Given this list of marker genes B4galt4, Alas1, Add1, Potegl, Pnp, Pde3a, Efna5, Plppr3, Surf2, Pias2, Npas2, Eri1, Asb13 (NCBI Gene Id 97892), Tril, Pou3f4 (POU domain, class 3, transcription factor 4), Ntaq1, Tcf4, Psca, Insrr, Prss22, Itgav, Stk25, Btaf1, Zfp207, Myzap, Rsf1, Zfp189, Ap1g1, Ube2h, Psmb1, Hddc3, Mga (NCBI Gene Id 99283), Paxbp1, Clint1, Srek1, Abhd15, Sparc, Ivl (NCBI Gene Id 68605), Masp2, Rab6a, Cux1, Pou2af3, Dhrs1, Plekha3, Col4a3, Trim65, Pet100, here is a description of the gene set: Mouse Gene Set: MIR_299A_3P_MIR_299B_3P from publication Chen Y, Wang X (PMID 31504780) Genes predicted to be targets of miRBase v22 microRNA mmu_miR_299a_3p, mmu_miR_299b_3p in miRDB v6.0 with MirTarget v4 prediction scores > 80 (high confidence targets). studied in species Mus musculus